The following is a description of a gene set: A synapse that lacks an electron dense postsynaptic specialization. In vertebtrates, these occur primarily on dendrite shafts and neuronal cell bodies and involve persynapses containing clusters of predominantly flattened or elongated vesicles and are typically inhibitory. species: Mus musculus Mouse Gene Set: GOCC_SYMMETRIC_SYNAPSE, and this is the list of marker genes: Ntsr1, Mkln1, Slc4a8, Igsf9b, Iqsec3, Chrm2, Septin11 (NCBI Gene Id 67780), Arfgef2, Penk